Given this list of marker genes PLAT, MYH9, ZP1, TPST2, ASTL, NLRP5, ZP4, ZP2, here is a description of the gene set: Human Gene Set: GOBP_NEGATIVE_REGULATION_OF_FERTILIZATION studied in species Homo sapiens Any process that decreases the rate, frequency or extent of fertilization. Fertilization is the union of gametes of opposite sexes during the process of sexual reproduction to form a zygote. It involves the fusion of the gametic nuclei (karyogamy) and cytoplasm (plasmogamy).